Given this list of marker genes Rab3ip (RAB3A interacting protein), Exoc2 (exocyst complex component 2), Rho, Exoc1, Rab11a, Rab8a, Cngb1, Exoc7 (NCBI Gene Id 53413), Cnga4, Asap1, here is a description of the gene set: electronically inferred by orthology from the curated human pathway Reactome Pathway: VxPx cargo-targeting to cilium This event has been computationally inferred from an event that has been demonstrated in another species.<p>The inference is based on the homology mapping from PANTHER. Briefly, reactions for which all involved PhysicalEntities (in input, output and catalyst) have a mapped orthologue/paralogue (for complexes at least 75% of components must have a mapping) are inferred to the other species. part of: Cargo trafficking to the periciliary membrane species: Mus musculus